The following is a description of a gene set: Human Gene Set: MIR346 from publication Chen Y, Wang X (PMID 31504780) Genes predicted to be targets of miRBase v22 microRNA hsa-miR-346 in miRDB v6.0 with MirTarget v4 prediction scores > 80 (high confidence targets). species: Homo sapiens, and this is the list of marker genes: BORCS8, GRM7, SLC38A4, AUTS2 (NCBI Gene Id 26053), CBLL1, ALDH1L2, FAN1, CCDC141, ARPIN-AP3S2, ZFC3H1, RFLNB, GID8, DLG2, NCOA7, AP3S2, LHX6, WNT9B, RDX, NXPH1, LRRC4C, CLDN11, PAK1IP1, ZDHHC13, PHC1, SMYD3, KCMF1, SPDYE3 (speedy/RINGO cell cycle regulator family member E3), SELENOK, NIN, AP5M1, TULP4, SLAMF1, RCN1, LINC03042, ST3GAL1, KLF4, COL2A1, SPDYE2B, NAALAD2, CALHM5, PROK1, SLC36A2, ATP1A2, ASPHD2, LPIN1 (lipin 1), POU2F1, ROR1, ING3, ACVR2B, RIMS2, ZNF609, ADAMTS17, EIF3J, LDAH, BORCS5, BCL6, MRPS9, ERI3, RBM39, ICA1L, FBXL2, NHERF1, NFIB, SPRYD7, KCNH6, SHANK2, PGK1, PYDC1, ZC3H12C, SPDYE2, YTHDF1, KSR2, IP6K3